Given this list of marker genes PPARGC1A, PMAIP1, MAPK3, PRKAB1, PRKAA2, PARP2, PRKAG3, PRKAB2, PRKAG1, RPS6KB1, MTOR, SIRT1, RPTOR, PRKAG2, MDH1, PRKAA1, MLST8, here is a description of the gene set: Age-related macular degeneration Human Gene Set: WP_AGERELATED_MACULAR_DEGENERATION studied in species Homo sapiens